Given this list of marker genes ACVR2A, ATP13A3, FRY, STING1, IFFO1, PABPC1L2B, SORL1, ARHGAP19, KIAA0513, FAM131C, MAPK14 (mitogen-activated protein kinase 14), SLC2A3, GSK3A, SP1, PSME3, SIGLEC1, PRR29, TET2, LASP1, FIGNL2, EYA3, NABP2, RBMS3, MMACHC, PABPC1L2A, GMPPB, FGD1, FBXO45, SMG6, NUDT18, STUM, PAICS, YEATS4, ST3GAL1 (NCBI Gene Id 6482), MIP (major intrinsic protein of lens fiber), CDK5R2, DLX6, CERS2, PPP1R12B, LPXN (NCBI Gene Id 9404), NOVA2, ALOXE3, RNF169, IGSF8 (NCBI Gene Id 93185), GJB3, CDK1, INTS6, FOXL2NB, CANX (NCBI Gene Id 821), IGF1R, TRIM16, MICALL1, SHF, GABRG2, ATP1B2, SMAD3, ETF1, KIF5A, NYNRIN, NEMP2, PARD3B (par-3 family cell polarity regulator beta), SYNGAP1, RAB5B, DEFB118, LURAP1, CD34, TAB1, NIPSNAP1, KLK4, SNX33, GPATCH8, CSNK1G1, MECP2, AGAP1, WBP2, SHMT2, TMEM169, NME9, F9, RGSL1, BCL11A, CASTOR2, MVB12B, CHRDL1, IL2RG, ZNF703, CLSTN3 (NCBI Gene Id 9746), ADGRF2P, TUBB, PIANP, JADE2, POU2AF1, NXF1, VTI1A, STX2, ARL8A, KSR2, AKAP13, KIF24, SPRY4, RPH3A, ABHD2, WDTC1, SLC25A24, BAZ2A, TOLLIP, ZFPL1, ZNF395, FRMPD3, SIX2, CACNG6, RCOR1, ALKBH1, PLXNA4, C20orf96, OSBP, RAB11FIP1, GATAD2B, GTF2A1, GEN1, BICDL1, ADAM19, UBL4A, KRT75, DUSP26, MSI1, PADI2, LENG8, CCDC184 (coiled-coil domain containing 184), TTYH3, LSAMP, SHB, SHE, HYCC2, ATAT1, PACS1, SLC19A3, XPR1, NOL4L, NOTCH3, IL10RA, EIF4EBP1, LDLRAD3, ZNF583, IL18R1, LINC03040, MAPRE1, KCND1, ZNF782, KCNF1, TMEM63A, VCF2, PTMS, SHLD1, ELMOD1, LRATD2, TET3, KDELR2, CENPP, CERS3, KCNQ4, TRIM16L, SPINK14, SAMD9, DNMT3B, CLTA, ENAM, UBQLN2, DTX4, SMOC1, S100A16, KLC4, BPIFB2, ATP6V1B2 (ATPase H+ transporting V1 subunit B2), NFIX, PAK3, NELFE, RSPO4, CREB3L1, XYLB, RASSF3, DNAH8, DCX, IKBKE, LHX2, CWC27, MSH5, CAMKMT, NAA50, PLA2G2D, SDK1, MAPKAPK2, MPIG6B, ERI3, here is a description of the gene set: from publication Chen Y, Wang X (PMID 31504780) species: Homo sapiens Human Gene Set: MIR4510 Genes predicted to be targets of miRBase v22 microRNA hsa-miR-4510 in miRDB v6.0 with MirTarget v4 prediction scores > 80 (high confidence targets).